Given this list of marker genes Mmp10, Il1rl1, Mgst1, Cav1, Car3, Flnc, Mvd, Vim, Cd44, Spry1, Hbegf, Lbh, Plaur, Bcl3, Spp1, Stmn1, Ptgs2, here is a description of the gene set: Mouse Gene Set: MATTHEWS_AP1_TARGETS Known targets of AP1 that were down-regulated by overexpression of TAM67, a dominant-negative form of JUN. from publication Matthews CP, Birkholz AM, Baker AR, Perella CM, Beck GR Jr, Young MR, Colburn NH (PMID 17363560) species: Mus musculus Activation of activator protein 1 (AP-1) and nuclear factor kappaB (NFkappaB)-dependent transcription is required for tumor promotion in cell culture models and transgenic mice. Dominant-negative c-Jun (TAM67) blocks AP-1 activation by dimerizing with Jun or Fos family proteins and blocks NFkappaB activation by interacting with NFkappaB p65. Two-stage skin carcinogenesis experiments in a model relevant to human cancer risk, transgenic mice expressing human papillomavirus 16 E7 oncogene (K14-HPV16-E7), show E7-enhanced tumor promotion. A cross to K14-TAM67-expressing mice results in dramatic inhibition of tumor promoter-induced AP-1 luciferase reporter activation and papillomagenesis. Epithelial specific TAM67 expression inhibits tumorigenesis without affecting TPA- or E7-induced hyperproliferation of the skin. Thus, the mouse model enriches for TAM67 targets relevant to tumorigenesis rather than to general cell proliferation or hyperplasia, implicating a subset of AP-1- and/or NFkappaB-dependent genes. The aim of the present study was to identify target genes responsible for TAM67 inhibition of DMBA-TPA-induced tumorigenesis. Microarray expression analysis of epidermal tissues revealed small sets of genes in which expression is both up-regulated by tumor promoter and down-regulated by TAM67. Among these, cyclooxygenase-2 (Cox-2/Ptgs2) and osteopontin (Opn/Spp1) are known to be functionally significant in driving carcinogenesis. Results identify both Cox-2 and Opn as transcriptional targets of TAM67 with CRE, but not NFkappaB sites important in the Cox-2 promoter and an AP-1 site important in the Opn promoter.